Given this list of marker genes TFDP1 (transcription factor Dp-1), RTRAF, PLOD2, FBLN2, LSM12, PIP5K1C, CANX, CCDC43, GABRP, SCYL1, FASTKD2, CIBAR1, TMED10, APOE, RAB6A, PADI3, EFNA3 (NCBI Gene Id 1944), MGAT2, ELN, GNMT, HMGB1, QNG1, TIMMDC1, SOX5, MARCKS, USP18, TAOK1, SPESP1, INTS9, ERC1, PLK1, PDE4DIP, KRT33B, CTNNBIP1, UBE2F, GCLC, SLC39A11, CALD1, ZNF148, CAP1, TRBV28, PINLYP, MBD3L2, SMAD4 (NCBI Gene Id 4089), KRT32, LYAR, CDH3, BASP1, PABPN1, RYR1, RIOK2, RASSF3, ZDHHC14, NDEL1, UBL5, NCAPD2, TCEAL3, KRTAP19-1, CPSF4, FRMD4B, SLC35B1, KRTAP6-1, GALNT11, ECE1, KERA, LDHB, RPS6 (NCBI Gene Id 92956), FHDC1, S100A3, EIF3E, EPRS1 (NCBI Gene Id 2058), RMND5B, CALR, RILPL2, WDR12, CAPN6, CELF4, IMPACT, RPN2, IAPP, RPS17, MBP, COL18A1, NHERF2, SNX30, SAFB2, POU1F1, DLX1, C6orf132, RHOG, SPON1, CTNS, PKIG, SLC44A1, EPHA5, SEPHS2, TPR, VAMP8, MT1F, TRO, PMEL, GOLGA4, POLR3A, CRYBA4, MYBL2, PHB2, DMD, HACD2, CERS4, LAMA2, CRIM1, NME7, ALDH3A1, KRTCAP2, KRT75, LPCAT1, KRT71, FXYD4, THRA, AQR (aquarius intron-binding spliceosomal factor), SPTBN2, KRTAP15-1, RDH11, SLC39A14, SAP18, PMEPA1, H2BC5, KRT31, ENC1, S100A14, KRTAP9-4, ACTC1, FBP1, HSPA8, MAN2B1 (NCBI Gene Id 4125), MGLL, RNASET2, APBA3, EDN3, ATF1, ATP6V0C, EGFR, SNRPG, RPL37A, EDARADD, KRT17 (keratin 17), TNNI1, CHD4, RPS21, GSDMA, ELOVL6 (ELOVL fatty acid elongase 6), RASL11B, NDUFA2, SLC39A6, IRX4, COL6A2, XPO5, TRH, KDM5B, KRT33A, SNCA, TEX261, CAMK2B, INTS6L, SMARCD2, COL1A1, KRTAP9-9, PDE3A, PIWIL2, RPL3L, SFXN3, PATZ1, NAV2, SFRP2, CDKN1C, PDAP1, PJA1, HR (HR lysine demethylase and nuclear receptor corepressor), DSTYK, RPS8, GLIPR1L2, BBIP1, UCP2, RPS7, DLK1, KRT72, POLDIP3, ST14, TNRC6A, SLC45A3, GLO1, SP110, COL11A1, PRELP, TG, FOXC1, KRT79, SHMT1, RETREG3, HOOK2, KRTAP20-1, ETHE1, GALR1, TCHH, SLC35A2, SCMH1, RIOK3, PANK1, PURB, MYH14, HHIP, KMT5A, ESRP1, KRTAP19-3, H2BC13, MGA, TJP2, POLG, MIS12, NDUFA5, MSX2, TNMD, MTF2, ERRFI1, HRAS, PAM16, NFE2L3, KRT27, NPEPL1, IGDCC4, SUPT6H, MIF4GD, RBBP8, FLNA, ACVR2B, MRPL39, RHBG, KRTAP1-3, KRT36, MAX, POM121, KRTAP4-5, RBFOX2, IFFO2 (NCBI Gene Id 126917), EFNB1, PEG3, NCOA5, ELOVL3, NCDN, KRTAP19-5, GRK4, PAX6, LGR5, AP4S1, ATXN7L3B, HACD4 (3-hydroxyacyl-CoA dehydratase 4), HMGA1, HERC6, PSORS1C2, CELF1, PRNP, SLC27A4 (solute carrier family 27 member 4), LAD1, PRMT5, BRD3, MAP4, YPEL1, WFDC21P, KRT85, HJURP, PGD, CCND2, KRTAP4-11, CCDC137, GJB6, RHBDL3, PRSS12, GJB2, SLC5A6, ABCE1, TOR2A, UBC, CEBPG, GTF2B, CCDC71, TMEM131L, PTPRE, KLK10, RPL37, FZD7, PTGDS, MYH1, SIAH1, PFN2, EFTUD2, CEBPB, TRIM2, HIPK2, ANK3, USP19, SOX11, ECRG4, DNAJC17, IDI1, KRTAP12-2, CX3CR1 (C-X3-C motif chemokine receptor 1), DKK2, NPY, TNNT1, MTREX, SMARCA4, MRTFA, KRT34, C1D, INCENP, TNFRSF19, COPS9, BAMBI, HOMER2, MISP, VDR, MCL1, NFIB, PIGQ, CCNL1, TRIP13, ADGRG1, FZD6, MYH6, LSR, CLNS1A, PKP2, KIF1C, LAMA5, CYP2G1P, UBLCP1, DNPH1, FUBP1, DCT, NFIA, NDUFA3, RPL31, FKBP5 (NCBI Gene Id 2289), ZMYND11, SCARA3, LY6G6D, AATF, MRPL52, GAS1, CXCL14, DLX3, MAGOHB, FRYL, KRT35, MEIS2, TARDBP, LTBP1 (latent transforming growth factor beta binding protein 1), GGT1, DUS1L, ATP5IF1, LMTK2, WDR75, TCF20, BMERB1, UNC5B, FOXO1, WRN, PLEC, RPL23, C22orf39 (chromosome 22 open reading frame 39), KAT7, KRT25, RIPK4, DIAPH3, TGS1, KRTAP3-1, ZSCAN26, TPO, PCOLCE, CDK2AP1, FADS3, RPL27, GRHL1, CUX1, KRTAP8-1, ACSL5, CLK1, BAALC (NCBI Gene Id 79870), EXTL3, RHOV, TFAP2B, EGR2, RHOU (ras homolog family member U), SRRM1, OS9, MARCKSL1, PIP, BICC1, BCR, ATF7IP2 (activating transcription factor 7 interacting protein 2), AFF2, RNF149, RRAD, PTPRF, WNT5A, RPL21, XIST, NR2F1, MKI67, NOTCH1, IGFBP2, SET, EDC4, GDPD3, ATP5PD, POLR2L, TMCC3, PIGU, RTP4, TNNC1, MLLT1, AARS1, RPL26, NEO1, EIF4EBP1, WWC1, CRTC3, ARHGEF25, CYP17A1 (cytochrome P450 family 17 subfamily A member 1), KRTAP5-4, TENM4, CCT6A, SSBP2, TENM2, UBQLN4, FAAP20, CES4A, CELSR2, ZNF574, KRT82, G6PD, MAP3K5, KRT83, CLIP4, FBN2, ABCA2 (NCBI Gene Id 23153), SON, TC2N (tandem C2 domains, nuclear, NCBI Gene Id 123036), ZCCHC9 (NCBI Gene Id 84240), DNAJC3, SLC7A5, HMGCS1, SOX9, MYO10, NKD2, SF3B2, PDCD7, AURKC, APP, FA2H (fatty acid 2-hydroxylase), RDH10, KRTAP13-2, MAN2C1, KRT86, CLU, CLCN3, RBM6, HOPX, DDR1, ALDH1A3, HUWE1, IGFBP4, RBBP4, SMAD1, TLE3, STX18, PCBP2, SRSF3, FOXP1, NEUROD4, ZNF280D, AGFG2, MYH3, SPRR1A, SCYGR1, AGPAT1, RAB12, STRBP, CXXC5, PPIH (peptidylprolyl isomerase H), GNA13, HOXA3, ZFP36, CRYM (crystallin mu), LIG3, CD248, RPL14, MT4, ACAN, CTNNAL1, CCT2, PPIB, RRN3, ITPR3, KRT23, CA6, LASP1, CHAC1, EPHX1 (epoxide hydrolase 1), LTBP2, CRYL1, PLCB1, SF3A2, SIVA1, LGALS7 (galectin 7, NCBI Gene Id 3963), JUNB, RBBP6, BRD2, PMFBP1, MRPL33 (NCBI Gene Id 9553), ADAMTS4, THRAP3 (thyroid hormone receptor associated protein 3), WRAP73, ERO1A, SMO, AMMECR1L, NHSL1, ATP11A, PPCDC, SHISA2, UBE3A, COL9A3, CAMKK2, PIGB, CWH43, OVOL1, ILF3, RETNLB, SDHAF4, TECR, MSH4, SREK1, RCC2, DPYSL3, C1R, SCAF11 (SR-related CTD associated factor 11), PPP4R3B, PSMC4, PKD1, YIPF4, KRTAP4-1, CACFD1, CDKN1A, APLP2, TIA1, NUMA1, TNNT2, RAB4A, LCE1A, NDUFAF7, GIP, MT1X, SLC25A10, SNTB2, CENPA, ZMYM4, TIMP3, CSNK1D, FGF7, RARG, RPS24, CLEC10A, TOMM70, PROKR1, SH3RF1, SOX2, RPL34, MTA1, POLR2A, CALHM5, CPT1A, NTN1, ATM, PTTG1IP, PDS5A, PTPN13, BACH2, DOP1B, TMOD2, CCND1 (cyclin D1), RPS18, GSTP1, KRTAP19-8, UPP1, ENOX2, KPNA6, RPS25, PLXNB3, DYNLT1, MASP1, FKBPL, MFAP3, MAML1, KRT81, GPRC5D, RIMS2, KRTAP5-2, NECTIN2, PLXNA2 (plexin A2), SPINT1, BACH1, here is a description of the gene set: Genes down-regulated in mice with skin specific double knockout of both RB1 and TP53 by Cre-lox. Human Gene Set: MARTINEZ_RB1_AND_TP53_TARGETS_DN species: Mus musculus from publication Martínez-Cruz AB, Santos M, Lara MF, Segrelles C, Ruiz S, Moral M, Lorz C, García-Escudero R, Paramio JM (PMID 18245467) Squamous cell carcinomas (SCC) represent the most aggressive type of nonmelanoma skin cancer. Although little is known about the causal alterations of SCCs, in organ-transplanted patients the E7 and E6 oncogenes of human papillomavirus, targeting the p53- and pRb-dependent pathways, have been widely involved. Here, we report the functional consequences of the simultaneous elimination of Trp53 and retinoblastoma (Rb) genes in epidermis using Cre-loxP system. Loss of p53, but not pRb, produces spontaneous tumor development, indicating that p53 is the predominant tumor suppressor acting in mouse epidermis. Although the simultaneous inactivation of pRb and p53 does not aggravate the phenotype observed in Rb-deficient epidermis in terms of proliferation and/or differentiation, spontaneous SCC development is severely accelerated in doubly deficient mice. The tumors are aggressive and undifferentiated and display a hair follicle origin. Detailed analysis indicates that the acceleration is mediated by premature activation of the epidermal growth factor receptor/Akt pathway, resulting in increased proliferation in normal and dysplastic hair follicles and augmented tumor angiogenesis. The molecular characteristics of this model provide valuable tools to understand epidermal tumor formation and may ultimately contribute to the development of therapies for the treatment of aggressive squamous cancer.